Given this list of marker genes STAT5B, GAB2, FGF6, FGF9, CNTRL, CUX1, ERLIN2, SOS1, GRB2, FRS2, FGF1, TRIM24, FGFR1OP2, LRRFIP1, PLCG1, STAT3, KRAS, FGF5, CEP43, CPSF6 (cleavage and polyadenylation specific factor 6), FGF4, FGF2, PIK3CA, FGF17, BCR, ZMYM2, BAG4, FGFR1, NRAS, GAB1, FGF20, MYO18A, STAT1, FGF8, FGF23, HRAS, STAT5A, PIK3R1, here is a description of the gene set: The FGFR1 gene has been shown to be subject to activating mutations, chromosomal rearrangements and gene amplification leading to a variety of proliferative and developmental disorders depending on whether these events occur in the germline or arise somatically. <br><br><br>Activating mutation P252R in FGFR1 is associated with the development of Pfeiffer syndrome, characterized by craniosynostosis (premature fusion of several sutures in the skull) and broadened thumbs and toes. This residue falls in a highly conserved Pro-Ser dipeptide between the second and third Ig domains of the extracellular region of the receptor. The mutation is thought to increase the number of hydrogen bonds formed with the ligand and to thereby increase ligand-binding affinity. Unlike other FGF receptors, few activating point mutations in the FGFR1 coding sequence have been identified in cancer. Point mutations in the Ig II-III linker analagous to the P252R Pfeiffer syndrome mutation have been identified in lung cancer and melanoma, and two kinase-domain mutations in FGFR1 have been identified in glioblastoma.<br><br>In contrast, FGFR1 is a target of chromosomal rearrangements in a number of cancers. FGFR1 has been shown to be recurrently translocated in the 8p11 myeloproliferative syndrome (EMS), a pre-leukemic condition also known as stem cell leukemia/lymphoma (SCLL) that rapidly progresses to leukemia. This translocation fuses the kinase domain of FGFR1 with the dimerization domain of one of 10 identified fusion partners, resulting in the constitutive dimerization and activation of the kinase. <br><br>Amplification of the FGFR1 gene has been implicated as a oncogenic factor in a range of cancers, including breast, ovarian, bladder, lung, oral squamous carcinomas, and rhabdomyosarcoma, although there are other candidate genes in the amplified region and the definitive role of FGFR1 has not been fully established.<br>More recently, FGFR1 fusion proteins have been identified in a number of cancers; these are thought to undergo constitutive ligand-independent dimerization and activation based on dimerization motifs found in the fusion partners. studied in species Homo sapiens part of: Signaling by FGFR in disease Reactome Pathway: Signaling by FGFR1 in disease